Given this list of marker genes SPRED2, GPR19, HDDC3, REEP1, FOXC2, THUMPD2, VIPR1, CCDC73, CTSE, DPP4, FPGT, RB1 (RB transcriptional corepressor 1), SQLE, IGF2BP2, GTF2A2, RECQL5, MESD, TSR1, METTL8, DAP3, C4BPA, GYS1, GPATCH1, SERPINB6, SFRP4, DYRK3, LHPP (NCBI Gene Id 64077), HEATR3, CENPI, TUFM, SMAP2, TRIB2, FBXO9, AIM2, PWP2, MTFP1, ATRN, CARMIL1, B3GALNT2, IFT172, CYBC1, GUF1, HOOK2, IGF2-AS, REV1, COL8A2, RBMX (RNA binding motif protein X-linked), CRIP3, STIMATE, SH3BP2, DGKQ, C7orf50, WHAMM, HTRA4, PDCD7, PDK3, DAAM1, ALS2CL, GEMIN4, OPTN, TYW5, TMEM186, MTMR14, ZBED3, MSRB2, CUTC, EZR, NUP93, CPLANE2, CABLES1, TPR, DRAM1, CDH1, TNKS, EGF, CYP26A1, DNAAF8, BLM, TWSG1, NEDD1, TMEM97, CASP4, ORC3, PAQR8, TAF1A, PARP8, UBE2L6, RPL36A, GBF1, CD44, CD9, RXFP1, ETV5, FUCA2, HDAC3, CDKAL1, SUPV3L1, LYSMD1, RNF6, C2orf76 (chromosome 2 open reading frame 76), RBMS2, MED11, LSM2, ALDH7A1, CRYZ, AHCYL1, DCLRE1A, MTUS2, CRTAM, SURF2, CD5, SETD2, FANCB, NPAS3, ENTPD6, ECPAS, TBC1D32, FAHD1, CCDC43, GALNT11, CYTH3, MRGBP, SLC15A2, ACSL5, COQ7, FANCI, ALOX5, RFTN1, P2RX4, ARSK (NCBI Gene Id 153642), IRX3, CABP7, C8orf33, PFKFB2, APOBEC1, SPINK1, SPTLC1, EPS8L1, S100A9, PDLIM1, SOD2, TEFM, EPPK1, SUPT7L, GPATCH11, ZER1, RIN2, PLAA, SWSAP1, SLC45A4, DDX51, PSIP1 (PC4 and SRSF1 interacting protein 1), INTS14, PEX11B, RABL3, CLK1, COQ10A, STXBP4, OBI1, TLR6, CCN2, BCL2L12, PAK6, DLL4, UBE3D, ARL4A, NSRP1, RPP40, PFKP, DSG2, TRAF1, RNASEH2B, ZNF823, HCRTR2, CCR3, CYRIA, RASSF3, XRCC6, KSR1, COG7, PECAM1, NOA1, NAIF1, AIRN, NFS1, MYC, MGST2, RFLNB, RAD51D, EBNA1BP2, TFDP1, CHPT1 (NCBI Gene Id 56994), TRDMT1 (NCBI Gene Id 1787), POLD2, CRLS1, PRKAR2A, LONRF1 (LON peptidase N-terminal domain and ring finger 1), CXCR3, SENP8, SCNM1, here is a description of the gene set: studied in species Homo sapiens CD8 T cells play a crucial role in immunity to infection and cancer. They are maintained in constant numbers, but upon stimulation with antigen undergo a developmental program characterized by distinct phases encompassing the expansion and then contraction of antigen-specific populations, followed by the persistence of long-lived memory cells. Although this predictable pattern of a CD8 T cell response is well established, the underlying cellular mechanisms regulating the transition to memory remain undefined. Here we show that TRAF6, an adapter protein in the TNF-receptor (TNFR) and IL-1R/TLR superfamily, regulates CD8 T cell memory development following infection by modulating fatty acid metabolism. We show that mice with a T cell-specific deletion of TRAF6 mount robust primary CD8 T cell effector responses, but have a profound defect in their ability to generate memory. This defect is CD8 T cell intrinsic and is characterized by the disappearance of antigen-specific cells in the weeks following primary immunization. Microarray analyses revealed that TRAF6-deficient CD8 T cells from early timepoints following immunization exhibit altered expression of genes that regulate fatty acid metabolism. Consistent with this, activated CD8 T cells lacking TRAF6 are unable to upregulate mitochondrial β-oxidation in response to growth factor withdrawal in vitro. Treatment with drugs that induce fatty acid oxidation enabled CD8 T cell memory generation in the absence of TRAF6. Remarkably, these treatments also increased CD8 T cell memory in wild type mice, and consequently were able to significantly improve the efficacy of an experimental anti-cancer vaccine. from publication Pearce EL, Walsh MC, Cejas PJ, Harms GM, Shen H, Wang LS, Jones RG, Choi Y (PMID 19494812) Genes up-regulated in comparison of wild type CD8 effector T cells at day 10 versus those from mice defficient for TRAF6 at day 10. Human Gene Set: GSE15750_WT_VS_TRAF6KO_DAY10_EFF_CD8_TCELL_UP